Given this list of marker genes SFRP1, TNC, PRKAA2, AKR1C3, CCL21, PTGDR2, AKT1, GNAS, PTGER2 (prostaglandin E receptor 2), CCR7, TNFSF4, GNB1, PTGER4, ANKRD13C, PRKAA1, PRKCE, AKR1C2, PTGFR, P2RY6, P2RY4, PTGDR, GNG2, ACACA, AKAP8, CCL19, ADCY6, here is a description of the gene set: studied in species Homo sapiens Any process that results in a change in state or activity of a cell (in terms of movement, secretion, enzyme production, gene expression, etc.) as a result of a prostagladin stimulus. Human Gene Set: GOBP_CELLULAR_RESPONSE_TO_PROSTAGLANDIN_STIMULUS